Given this list of marker genes Dlg2, Bsn, Tmem108, Hap1, Dst, Pafah1b1 (NCBI Gene Id 94322), Actr10, Ndel1, Sod1, Nefl, Map1a, Fbxw11, Mgarp, Kif1c, Mecp2, Snapin, Kif5b, Kif5a, Kif1a, Dync1h1, Agbl4, Caly, Agtpbp1, Kif1b, here is a description of the gene set: The directed movement of organelles or molecules along microtubules from the cell periphery toward the cell body in nerve cell axons. studied in species Mus musculus Mouse Gene Set: GOBP_RETROGRADE_AXONAL_TRANSPORT